Given this list of marker genes CILP2, ALPL, ALPG, ALPI, CILP, ALPP, here is a description of the gene set: species: Homo sapiens Catalysis of the reaction: a phosphate monoester + H2O = an alcohol + phosphate, with an alkaline pH optimum. Human Gene Set: GOMF_ALKALINE_PHOSPHATASE_ACTIVITY